The following is a description of a gene set: Catalysis of the removal of an amino group from a substrate, producing a substituted or nonsubstituted ammonia (NH3/NH2R). studied in species Mus musculus Mouse Gene Set: GOMF_DEAMINASE_ACTIVITY, and this is the list of marker genes: Adal, Adad2, Lacc1, Apobec1, Adat3, Apobec2, Cdadc1 (NCBI Gene Id 71891), Adat2, Ampd2, Gnpda1, Pycr3, Ampd3, Adar, Cda, Adarb1, Ampd1, Apobec3, Gda, Rida, Aicda, Gnpda2, Adad1, Ada, Zbp1, Dctd, Adarb2, Adat1